Given this list of marker genes TSC1, MITD1, PPIA, PNPLA1, TRMT12, ZBTB4, BRWD1, TOB1-AS1, CSKMT (citrate synthase lysine methyltransferase), SNORA24, RPS20 (ribosomal protein S20), RBBP4, SSBP2, H3C12, TUBA1B-AS1, EEF1D, CPNE2, TMSB10, WSB1, GTF2B, TOB1, TRDMT1, SAV1, RPL37A, RPL10, DHX30, ZNF689, MTBP, CEP95, CCDC97, GFI1B, MIR4766, AZIN2, NAGLU, JSRP1, SNORD55, TPI1, RPS7, COX16, RPL28, RPL4, RPL37A-DT, VARS2, SERPINB9, GTF3C6, NDUFS2, BTG1-DT, THRB-AS1, IER3, SMG8, H2BC17, STRIP1, COPS7B, RPS24, RNU5A-8P, H3C13, MIA3, SAMD9L, UBE2D3, CIRBP, APTX, MRPL13, SDC4, H2AX, EGR1, MIR3190, ATP1B2, G3BP1 (NCBI Gene Id 10146), ITPR1, UBE2S, NEU3, RFPL4B, ZWILCH, CARD8-AS1, RNVU1-6, NPL, CDC42SE1, CCDC144NL, SNORD43, SAT1-DT, RPL15, SUGP1, BAIAP2-DT, RPL29, EPC1-AS1, IPPK, TUBB3, SNHG12, SAR1B, PSMG3-AS1, SNHG25, CSRP1, CALR, MBTPS2, TMSB4X, PCAT14, BEX4, NLRP1, PEX3, H4C5, CCDC8, RNVU1-3, RNU5B-1, H2AC4, SFXN3, MAFA, SKP1, SNORD25, IFRD1 (NCBI Gene Id 95049), ZBTB8OS, EIF5, CCNI, MTRFR, SNORD104 (small nucleolar RNA, C/D box 104), H2AC6, RNU11, BRD2, MAF1, DNAJB1, ING1, LDHA, ATAD2, POU2F3 (NCBI Gene Id 25833), H4C3, TRAF7, ADARB1, VTI1A (NCBI Gene Id 143188), WDR74, GTF2H4, IMPACT, SFTA2, RPL13, MPLKIP, RTF1, PTGER3, LRP6, SNHG7, RNU5A-1, RNU2-63P, SLX9, MYLIP, RPS26, FSCN1, ODC1-DT, RPL12, NSL1, DDX5, COX20, UBB, DEPP1, SUGCT, TAF4, SAMMSON, ECE2, RPL11, NXF1, SNORD60, UQCRC2, PRDX2, CEBPB, RCOR3, NOL8, SLC25A5-AS1, NASP, RNU1-1, EEF1A1 (NCBI Gene Id 96648), GPANK1, HSPA1A, IER5, RPL38, FBXL13, ZBTB45, MRPL39, AFF1, SNORD27, NUP62, FASN, PPT1, CEBPA-DT, AP1G1, UAP1, SEC24C, LINC01719, ZSCAN16-AS1, HSPA1B, EHD1, EOGT, CARS2, MTF2, IPO9-AS1, VGF, MARCHF7, GABPB2, RPL18, MBD6, PPP5D1P, HEMK1, NMNAT1, LINC01547, SENP6, LINC00869, NUSAP1, SOCS1, TFAP2A, PABPC4, KCTD10, PXN-AS1, RNU4-2, TCF3, ACTB, RNVU1-26 (RNA, variant U1 small nuclear 26), SLC20A1-DT, FOSB, SNORD48, H2BC11, SLC25A5, ZC3H6, MKNK2, SH2B1, NFE4, AK2, TUBB2A, RIN3, PTPN7, H2AC11, RNVU1-2A, RNVU1-4, SLC25A4, MIR5087, RPS12, SYT7, PPP1R10, PDE4DIPP6, SNHG1, LZIC, HMGN2, CSNK2B, MRPL48, SNHG19, RPS5, JARID2-DT, NKIRAS1, UFL1, SNHG9, PRDX1, MALAT1, SOCS3-DT, CYCS, CYTH2, SNORA78, SNORD54, ZSCAN31, H2AC17, RNVU1-21, RNU1-108P, SNHG17, RRM2, RPS2, PCBP1-AS1 (NCBI Gene Id 652470), SGK1, NOL7, SNHG5, RNVU1-25, H1-10, PABPC1, GEMIN6, SLC4A1AP, JPT1, BRPF3, MAIP1, RNVU1-22, ATF3, TATDN3, H2BC4, SS18, MIR4754, SNORD26, C11orf98, RNVU1-28, TTI2, OAZ1, SSR4P1, HSP90AA1, SLC20A1, LRSAM1, DNAJB4, LINC02934 (long intergenic non-protein coding RNA 2934), SNAI1, HLA-E, RNU5E-1, FRG2FP, MIR548AW, ENSG00000206898, MCL1, NCKAP5L, ENSG00000251574, BMS1, USPL1, C6orf89, CALM2, LINC02252, TYW5, HCG21, RNVU1-2, C17orf75, RADIL, ZFP36, MIR142HG, TMEM14B, RPL23AP53, RNU5E-4P, DUSP1, FUS, OIP5, TMED1, ITPR1-DT, ENSG00000283078, RNVU1-15, H3C1, BMS1P4-AGAP5, PRKAR1B, UAP1-DT, SFPQ, SEC14L1 (SEC14 like lipid binding 1), SELENBP1, SNORD46 (NCBI Gene Id 94161), TANK-AS1, JUNB, RPS3, LINC01476, HUS1 (NCBI Gene Id 3364), ZC3H12A, C19orf38, BANCR, TNRC6C, DDR1, RNU12, CRYBG2, DYNC1LI1 (dynein cytoplasmic 1 light intermediate chain 1), CCN1, LINC01610, SNORD68 (NCBI Gene Id 606500, small nucleolar RNA, C/D box 68), FOS, SPDYC, CA8, BTBD1, TMPO, RPL10A, SNORA57, CDCA2, CCDC80, GLUL, MRFAP1L2, SELENOP, ARPC5L, SNORA16A, EFCAB7, MIR4515, MFSD11, RNU5D-1, CDKN1A, EIF4A2, OPLAH, ZNF596, GADD45B, BMS1P4, SLC35A3, SNORA50C, UBC, MAT2A, PPP1R15A, RNVU1-27, SLC25A6, NSD1, VDAC2, PLEKHM3, SUPT7L, EXT1, CBX5, HERPUD1, HNRNPA1, SAT1, RIPK1, EIF1, NEAT1, RPL22L1, ACTG1, DNAJA1, MCU, RNU5F-1, CCDC136, TUBA1B, NBPF12, JUND, SNORD101 (NCBI Gene Id 594837), MYC, RPS18, LITATS1, CTNNB1, FAM53C, RNVU1-29, KLF6, THRB, HP1BP3, NPM1, SNORD13, SEC13, SNORD50B (small nucleolar RNA, C/D box 50B), ADAT2, LINC00240, SQSTM1, ID1, PTPN21, TUBA1C, TIMM50, RPSA, SLC9A1, ZNF143-AS1, LBH, CERNA3, LINC00624, PRMT1, SNHG6, SLC16A1-AS1, RNVU1-23, GADD45G, RNVU1-19, AJUBA-DT, ENSG00000228395, PLXNA3, RNVU1-30, CLPX, RNU7-1, GDI1, RNU2-2P, CCDC144NL-AS1, TPI1P2, CCNG2, IL4I1, ZNF518A, POLR2A, SNORD15A, RNVU1-31, GTF3C5, RPL35, LINC01029, H2AZ1, SLC13A3, MAU2, TRAF3IP2-AS1, LINC01732, PDE6D, SRSF2, ODC1, RPS6 (NCBI Gene Id 92956), C16orf46-DT, AMD1, CLASP1, EEF2, RBL1, MAILR, ANXA2, PSMG3, BCDIN3D-AS1, ENSG00000273727 (U1 spliceosomal RNA), H4C2, RNVU1-34, EGFL7, UBE3B, PLAG1 (NCBI Gene Id 7996), GOLGA3, TFRC, HES1, MRPL30, AJUBA, KMT5B, POLDIP3, SLC16A1, ZSWIM6, RPL3, TUBB4B, TNFSF9, JARID2, CEBPA (NCBI Gene Id 1050), TMA16, RPS3A, C16orf46, KCTD9, RPS8, THEM4, ZNF143, SRSF7, EPC1, CALM3, PIM3, RNVU1-18, BAIAP2, DDIT3, MIDN, LSM10, ID2-AS1, NDUFS7, BTG1, GLUD1P3, ALG3, RPL8, SPTAN1, RPLP1, EIF2D, TVP23B, PRKAR2B-AS1, SHARPIN, RNU4-1, C12orf57, IKBKB-DT, KDM4B, TIGD5, RPL36 (ribosomal protein L36), CHCHD7, TENT5C-DT, SNHG32, ID2, REV3L, NOSIP, LINC02506, ITGB3BP, MIR3188, HSPA1L, SLC7A5P2, H2BC18, H2AZ1-DT, HOMER1, UCA1, NRIP3-DT, POLR3D, RPLP0, ASAP3, RPL24, ARL15 (NCBI Gene Id 54622), H1-4, DDX3X (DEAD-box helicase 3 X-linked), SRSF3, SLC27A5, SOCS3, SMG1P3, UBE2D3-AS1, SRSF6, MIR320A, LINC00824, H3-3B, ATF4, MRPS18B, PACSIN2, GPSM3, PSMC3, FTL, VPS52, HSP90AB1, UBIAD1, CALM1 (NCBI Gene Id 801), RNU5E-6P, RNVU1-7, CENPP, TULP2, SNORD118, ZDHHC6, SLC3A2, DHRSX, MIR5188, NRIP3, RGS2, ENSG00000275765, RPS9, C19orf48P, KDM5C, KMT2A, ATF7IP2, DIP2A, SNHG8, PIK3R3, TANK (TRAF family member associated NFKB activator), RNU4ATAC, ENSG00000221040, SNRNP27, RPS27, CSRP1-AS1, ATF5, SNHG20, CLASRP, REN, RNVU1-14, TNPO3, AZIN1, VIM, GNG4, PIEZO1, SPHK2, MIR4522, MAG, here is a description of the gene set: from publication Yevshin I, Sharipov R, Kolmykov S, Kondrakhin Y, Kolpakov F (PMID 30445619) Genes containing one or more binding sites for (GTF2A2) in their promoter regions (TSS -1000,+100 bp) as identified by GTRD version 20.06 ChIP-seq harmonization. species: Homo sapiens Human Gene Set: GTF2A2_TARGET_GENES